Given this list of marker genes Snw1, Med1, Taf11, Rxra, Ncoa6, Taf7, Tob2, Hr, Rxrb, here is a description of the gene set: Binding to a nuclear vitamin D receptor, a nuclear receptor that mediates the action of vitamin D by binding DNA and controlling the transcription of hormone-sensitive genes. studied in species Mus musculus Mouse Gene Set: GOMF_NUCLEAR_VITAMIN_D_RECEPTOR_BINDING